The following is a description of a gene set: An actin-rich adhesion structure characterized by formation upon cell substrate contact and localization at the substrate-attached part of the cell, contain an F-actin-rich core surrounded by a ring structure containing proteins such as vinculin and talin, and have a diameter of 0.5 mm. Mouse Gene Set: GOCC_PODOSOME studied in species Mus musculus, and this is the list of marker genes: Dnm2, Fscn1, Tpm4, Arhgef5, Adam8, Bin2, Cd2ap, Cttn (cortactin), Ccn5, Rhou, Actr2, Vcam1, Arhgef2, Dbnl, Actb, Tns3, Arap1, Amotl2, Kif9, Lcp1, Dock5, Asap1, Spata13, Fermt3, Actr3, Nos1ap, Wdr1, Plec, Ptpn12, Arpc2, Mapk8, Flna, Sh3gl1, Phldb2, Sh3pxd2b, Palld, Scn8a, Vcl, Tpm3, Hnrnpk, Afap1l1, Scin, Src, Erc1, Svil, Lpxn (leupaxin), Flii, Sh3pxd2a, Gsn